Given this list of marker genes Ccr2, Jam3, Ager, Plcb1, Cd47, Pdgfd, here is a description of the gene set: Any process that modulates the frequency, rate or extent of monocyte extravasation. species: Mus musculus Mouse Gene Set: GOBP_REGULATION_OF_MONOCYTE_EXTRAVASATION